Given this list of marker genes Tubb4a, Csnk1d, Ppp2r1a, Cep290, Pafah1b1, Hsp90aa1, Haus7, Cep152, Dctn1, Haus3, Cep43, Sdccag8, Tuba1a, Actr1a (NCBI Gene Id 54130), Csnk1e, Haus4, Dync1i2, Aurka, Sfi1, Clasp1, Ssna1, Nek2 (NCBI Gene Id 98226), Ywhae, Cep76, Cep250, Ofd1, Akap9, Cep164, Ckap5, Cep135, Odf2, Haus5, Cep192 (NCBI Gene Id 70799), Mapre1, Nde1, Cep63, Cep131, Tubb4b, Haus1 (NCBI Gene Id 225745), Prkaca, Tubg1, Cep78, Cep72, Dynll1, Haus6, Alms1, Cdk5rap2, Haus2, Dctn3, Hmmr, Cetn2, Cenpj, Cep70, Ninl, Tpx2, Plk4, Dctn2, Plk1, Tubb5, Haus8 (NCBI Gene Id 76478), Tuba4a, Cdk1, Dync1h1, Cep57, Ywhag, Nedd1, Ccp110, Cep41, Pcm1, here is a description of the gene set: AURKA Activation by TPX2 species: Mus musculus Mouse Gene Set: REACTOME_AURKA_ACTIVATION_BY_TPX2